The following is a description of a gene set: Mouse Gene Set: GOBP_POSITIVE_REGULATION_OF_ENDOPLASMIC_RETICULUM_STRESS_INDUCED_INTRINSIC_APOPTOTIC_SIGNALING_PATHWAY species: Mus musculus Any process that activates or increases the frequency, rate or extent of an endoplasmic reticulum stress-induced intrinsic apoptotic signaling pathway., and this is the list of marker genes: Ptpn2, Sirt1, Serinc3, Nck2, Spop, Nck1, Eif2ak3, Rnf183, Bok